The following is a description of a gene set: Enables the transfer of a solute or solutes from one side of a membrane to the other according to the reaction: solute(out) + Na+(out) = solute(in) + Na+(in). species: Homo sapiens Human Gene Set: GOMF_SOLUTE_SODIUM_SYMPORTER_ACTIVITY, and this is the list of marker genes: SLC6A6, SLC6A13, SLC10A6, SLC12A3 (solute carrier family 12 member 3), SLC6A20, SLC5A2, SLC6A9, SLC4A5, SLC5A12, SLC4A10, SLC6A1, SLC17A3, SLC6A18, SLC4A7, SLC6A2, SLC10A3, SLC4A4, SLC6A15 (NCBI Gene Id 59276), SLC6A7, SLC1A3 (solute carrier family 1 member 3), SLC38A3, SLC1A7, SLC10A4, SLC13A3, SLC12A2 (NCBI Gene Id 6558), SLC10A2, SLC1A6, SLC17A4 (solute carrier family 17 member 4), SLC10A5, SLC5A6, SLC29A1, SLC18A1, SLC22A1, SLC6A3, SLC34A2, SLC1A1, SLC6A4, SLC5A3, SLC13A4, SLC6A14, SLC5A10, MFSD2A, SLC17A8, SLC23A1, SLC4A9, SLC4A8, SLC5A9, SLC38A4 (solute carrier family 38 member 4), SLC5A5, SLC12A1, SLC28A1, SLC38A7, SLC17A2, SLC20A1, SLC28A2, SLC17A7, SLC10A1, SLC6A12, SLC5A7, SLC17A1, SLC38A1, SLC13A5, SLC17A6, SLC6A11, SLC23A2, SLC6A5, SLC34A1, SLC5A11, SLC5A8, SLC38A2, SLC5A4, SLC13A1, SLC34A3, SLC28A3, SLC6A8, SLC1A2, SLC18A2, SLC5A1, SLC13A2, SLC20A2